The following is a description of a gene set: species: Mus musculus A protein complex providing a discrete opening in a membrane that allows the passage of gases and/or liquids. Mouse Gene Set: GOCC_PORE_COMPLEX, and this is the list of marker genes: Tomm40l, Spg7, C9, Pdzd11, Ppif, Bax, Vdac1, C8g, C6, Tspan33, Slc25a31, Bak1, Vdac2, Bcl2, Adam10, Vdac3, Slc25a5, Hc, C8a, Slc25a4, C8b (complement component 8, beta polypeptide), Cd34, Tomm40, Plekha7, C7, Afdn